Given this list of marker genes KLK7 (NCBI Gene Id 5650), KLK3, KLK5, SPINK5, PGC, EVPL, here is a description of the gene set: Human Gene Set: GOBP_REGULATION_OF_ANTIBACTERIAL_PEPTIDE_PRODUCTION studied in species Homo sapiens Any process that modulates the frequency, rate, or extent of antibacterial peptide production.